Given this list of marker genes ITGA2, ELP4, BET1, ZFPL1, HAUS6, DNAJC5G (DnaJ heat shock protein family (Hsp40) member C5 gamma), DDC-AS1, L1TD1, SYCP2L, NMU, ANKRD35, PRKAB2, TLDC2, TOP1MT, E2F8, GATA4, KRT19, S100PBP, ACYP2, CPD, COX20, JAZF1-AS1, LMO7DN, TEDC2-AS1, GNAO1-DT, RHOJ, LINC01300, HAUS7, NSDHL, PMS1, DAZAP1, ANKRD33, MPPED2, SF1, MAML2, C1QTNF12, POU5F1P3, FAM227B, HDGF, SCAF11, S100G, MOCS2-DT, CLDN8, PIEZO2, KRTAP4-1, TMEM132D, CRIM1, TBC1D29P, VAT1L, FAM167A, DOK6, TEX46, SHB (NCBI Gene Id 6461), ZNF732, SRR (NCBI Gene Id 63826), FEN1, TFG, TNRC18, HKDC1, FNBP4, GRK3, RTN4RL2, RSAD1, CENPM, LINC02860, YME1L1, PAPSS1, NXPE3, TRPM5, APPBP2, SCOC-AS1, PRPS2, GALNTL5, FAM226B, RHBDL1, PGGHG, HOXC9, ZNF490, CA10, ATF6, SLC12A1, DLAT, PAFAH1B1, TMEM272, DCTN1-AS1, KIF18A, NIFK-AS1, ANP32A (NCBI Gene Id 8125), PLEKHH3, TGFB1I1, RAC1, HSP90AA1, MXI1, PRKACB, USP19, LRP8, INTS15, INSC, HSD17B6, WDR35, FCRLA, KLRC4, KAT5 (lysine acetyltransferase 5), ASB13, SRSF2, LINC02901, ZNF318, SERPINA4, IARS1, C1RL, ATP2C2, TTC27 (tetratricopeptide repeat domain 27), LINC00494, OSBPL1A, SMLR1, D2HGDH, DACH2, BPNT2, MAN2B2, TAOK2, GCKR (glucokinase regulator), C11orf71, ERF, NUDT16, CDS2, H1-5, FHIP2A, OPRK1 (opioid receptor kappa 1), PLA2R1, RFLNA, BOD1, LAT2, HECTD1, URB1-AS1, NPHS2, NIPA2, FOXH1, RIMS1, DCAF1, SNRNP27, AGXT, NEU2, GLS, PCDHA3, LTF (NCBI Gene Id 4057), B3GALT1, BOD1L2, TIMD4, MADCAM1, CD99P1, PDLIM3 (PDZ and LIM domain 3), PSG5, CYP2B7P, GTF3C2, NDUFA4L2, HCG4, AICDA, RXRG, SERP2, SLCO1C1, SMG1, TRPC3, CENPI, GMEB1, SORBS2, DHRS4-AS1, PLEKHB1, IFI27L1, RNASEH2B, AKR1C4, MFSD8, CDC6, KCNC2, MCF2L-AS1, CIAO1, LINC00511, HMGN4, NAALAD2, GARIN6, RILPL1, NDC80, AOC2, ADAM5, SIGLEC15, G6PC1, here is a description of the gene set: Genes down-regulated in wildtype bone marrow-derived macrophages: control versus treated with rosiglitazone. Human Gene Set: GSE25088_CTRL_VS_ROSIGLITAZONE_STIM_MACROPHAGE_DN species: Homo sapiens C57Bl/6 wild-type and STAT6 KO mice were used to study PPARg and IL-4 signaling. Bone marrow of 3 mice per group was isolated and differentiated to macrophages with M-CSF (20 ng/ml). 20 ng/ml IL-4 was used to induce alternative macrophage activation and 1 uM Rosiglitazone (RSG) was used to activate PPARg. From each mouse 4 samples were generated: 1. M-CSF, 2. M-CSF+RSG, 3. IL-4 and 4. IL-4+RSG. All compounds were added throughout the whole differentiation process, and frech media was added every other day. Control cells were treated with vehicle (DMSO:ethanol). After 10 days, RNA was isolated and gene expression profiles were analyzed using Mouse Genome 430 2.0 microarrays from Affymetrix. from publication Szanto A, Balint BL, Nagy ZS, Barta E, Dezso B, Pap A, Szeles L, Poliska S, Oros M, Evans RM, Barak Y, Schwabe J, Nagy L (PMID 21093321)